The following is a description of a gene set: from publication Chen Y, Wang X (PMID 31504780) Human Gene Set: MIR3908 species: Homo sapiens Genes predicted to be targets of miRBase v22 microRNA hsa-miR-3908 in miRDB v6.0 with MirTarget v4 prediction scores > 80 (high confidence targets)., and this is the list of marker genes: FUT9, RRM2B, RNF24 (NCBI Gene Id 51262), PCDHA13, HNRNPD, ZNF621, SLC5A7, TNKS, EBF2, PMS1, SMAGP, GAS1, PWWP2A, PCDHA2, EXT1, RAPGEF6, DDI1, CD44, UQCC6, COX5A, PCDHA7, SIK3, RANBP6, MBNL1, SPX, PALLD, YLPM1, CLGN, APP, YTHDC1, ADIPOR1, KIAA1143, CCDC47 (NCBI Gene Id 57003), VAPA, LNX2, TRIM37, PCLO, RGS10, C1orf141, PCDHA1, MOB1A, SLC1A3, TOX3, TRPC5, KLHL7, ZNF454, PCDHA5, BACH2, PCDHA6, RAB28, PCDHAC1, ANKRD44, SETBP1, MTMR10, PHF13, ARHGAP20, ESRRG (estrogen related receptor gamma), NALCN (NCBI Gene Id 93074), USP6NL, MORC3, HAO1, KIAA0408, PCDHA4, ZNF774, FRS2, MEGF10, TNPO1, MIER3, ERO1A, SUPT20H, NQO1, ADAM23, NMBR, TET1, ROBO2, PCDHAC2, ADAM22, ZHX1, RIMKLB, CAMTA1, GABPB2, NR1I2, TXNL1, PCDHA3, LRBA, LIN7C, ZBTB14, MPIG6B, ARHGAP5, CAP2, PRRC1, SYT14, EIF5A2, MICAL2, TSC22D1, COL19A1, PCDHA12, PCDHA10, ENTPD7, CDK6, DCN, CHPT1, PCDHA11, ZNF275, SRP72, BNIP2, LGALSL, ADGRB3, RSBN1, TNKS2, ZER1, GRB14 (NCBI Gene Id 2888)